Given this list of marker genes Mybbp1a, Ddx21, Smarca5, Baz1b, Dek, Sf3b1, Ercc6, Myo1c, here is a description of the gene set: Mouse Gene Set: GOCC_B_WICH_COMPLEX species: Mus musculus A chromatin remodeling complex that positively regulates histone H3 acetylation, in particular H3K9, by recruiting histone acetyltransferases to rDNA gene regions. Located in the nucleolus where it assembles on RNA Polymerase I (Pol I) and possibly on RNA Polymerase III (Pol III) promoter and coding regions during early G1 phase and activates the post-initiation phases of Pol I transcription. May also activate RNA Polymerase II (Pol II) gene transcription. In mammals, B-WICH contains the WICH complex core of BAZ1B and SMARCA5, additional protein subunits and possibly rRNAs. Although it contains several catalytic subunits it is not clear which functions are carried out by the complex itself.